The following is a description of a gene set: Human Gene Set: GOBP_UTERUS_MORPHOGENESIS The process in which anatomical structures of the uterus are generated and organized. species: Homo sapiens, and this is the list of marker genes: WNT7A, ASH1L, KDM5B, NIPBL, STRA6, WNT9B